The following is a description of a gene set: Human Gene Set: GOMF_PHOSPHOLIPID_TRANSPORTER_ACTIVITY Enables the directed movement of phospholipids into, out of or within a cell, or between cells. Phospholipids are a class of lipids containing phosphoric acid as a mono- or diester. studied in species Homo sapiens, and this is the list of marker genes: ABCA3, GLTPD2, CETP, XKR9, ATP8B1, PITPNM2, TMEM30B, PITPNA, TMEM30A, PLTP, PITPNM1, PLSCR1, PRELID3B, PLSCR3, ABCA4, ATP10A, TMEM63A, PCTP, ATP8A2, CLPTM1L, ATP11C, TMEM63B, ATP10B, CPTP (ceramide-1-phosphate transfer protein), ABCB1, PITPNC1, SERINC5, BLTP1, ATP11B, ABCA7, ANO6 (anoctamin 6), PLEKHA8P1, TNFAIP8L3, OSBPL8, OSBPL2, PITPNB, PRELID3A, VDAC2, ABCG1, ATP8B2, ATP8B3, OSBPL10, PLEKHA8, PRELID2, ATG9B, OSBPL5, PLSCR4, PLSCR5, SERINC2, MFSD2A, XKR4, TMEM63C, ESYT1, ANO9, C2CD2L, PRELID1, ABCB4, XKR8, GLTP, SCP2, ATP8A1, TRIAP1, CERT1, MTTP, ANO4, VMP1, TMEM41B, PITPNM3, PLSCR2, ANO3, ABCA1, SERINC3 (serine incorporator 3), ATG9A, ATP11A